The following is a description of a gene set: Mouse Gene Set: GOBP_NEGATIVE_REGULATION_OF_DENDRITIC_SPINE_DEVELOPMENT Any process that decreases the rate, frequency, or extent of dendritic spine development, the process whose specific outcome is the progression of the dendritic spine over time, from its formation to the mature structure. species: Mus musculus, and this is the list of marker genes: Nlgn1, Pten, Ptprs, Nlgn3, Plk2 (polo like kinase 2), Asap1, Ngfr, Apoe, Ngef, Hdac2, Mecp2, Grin3a, Dtnbp1, Ube3a (NCBI Gene Id 76097), Efna1, Fstl4, Dnm3